The following is a description of a gene set: Human Gene Set: GOBP_RESPONSE_TO_VITAMIN_K studied in species Homo sapiens Any process that results in a change in state or activity of a cell or an organism (in terms of movement, secretion, enzyme production, gene expression, etc.) as a result of a vitamin K stimulus., and this is the list of marker genes: F7, POSTN, BGLAP, F5, GAS6